The following is a description of a gene set: Genes down-regulated by trabectedin and its synthetic analog phthalascidin Pt 650 in HCT116 cells (colon cancer). species: Homo sapiens BACKGROUND: Ecteinascidin 743 (Et 743) is a potent antitumor marine alkaloid currently undergoing phase II clinical trials. The synthetic analog phthalascidin (Pt 650), a designed structural analog of Et 743 displays in vitro potency comparable to Et 743. In this study, we used a panel of 36 human cancer cell lines, flow cytometry and oligonucleotide microarrays to analyze further these two compounds in a parallel fashion with regard to both antitumor activity (phenotype) and gene expression (genotype) bases. RESULTS: The cancer panel experiment established that activity patterns of Et 743 and Pt 650 were essentially the same with their IC(50) values ranging from pM to low nM. By means of flow cytometric cell cycle analysis using HCT116 cells, they were shown to disrupt S phase progression after a 12-h treatment at 2.0 nM, eventually resulting in the late S and G2/M accumulation at the 24-h time point. Array-based gene expression monitoring also demonstrated that the Et 743 and Pt 650 profiles were highly similar in two distinct cancer cell lines, HCT116 colon and MDA-MB-435 breast. Characteristic changes were observed in subsets of genes involved in DNA damage response, transcription and signal transduction. In HCT116 carrying the wild-type p53 tumor suppressor gene, the up-regulation of several p53-responsive genes was evident. Furthermore, a subset of genes encoding DNA-binding proteins to specific promoter regions (e.g. the CCAAT box) was down-regulated in both cell lines, suggesting one potential mode of action of this series of antitumor agents. CONCLUSION: A combination of gene expression analysis using oligonucleotide microarrays and flow cytometry confirms an earlier finding that Et 743 and Pt 650 have remarkably similar biological activities. Human Gene Set: MARTINEZ_RESPONSE_TO_TRABECTEDIN from publication Martinez EJ, Corey EJ, Owa T (PMID 11755394), and this is the list of marker genes: SRPK2, HERC1, ALCAM, LRBA, ENOX2, GNAQ, SORL1, HMGA2, SMAD3, EIF4G3, COMMD1, ROR1, TCF12, EXT1, IRS1, CRADD, STK3, SPIDR (scaffold protein involved in DNA repair), MGMT, DDX10, BABAM2, ITPR1, XRCC4, DOCK1, POLA1 (DNA polymerase alpha 1, catalytic subunit), CUX1, GBE1, AP3B1, ID1, FTO, UVRAG, ADK, PPARG, NUMB, ZFHX3, ATF6, NCOR2, LPP, SND1, MARF1, KIFAP3, ME1, MLLT3, PTPRK, CRYBG1, KANK1, TIAM1, PCCA, TMEM131, PTPRG